Given this list of marker genes VEGFD, BRK1P1, UBE2E4P, NPM1P9, MIR6089, MSL3-DT, RN7SKP290, RPS6KA3, HCCS, RPS27AP17, PDHA1, TXLNG, SH3KBP1, RNU4-6P, RPL30P15, DRAXINP1, PDCL2P1, VCX, RPS5P8, HADHBP1, NHS-AS1, LINC03113, SMS (spermine synthase), TMSB4X, HIKESHIP1, FAM9CP1, RNU6-266P, SMPX, ENSG00000201467, MTND6P12, ASB9, LIMK2P1, RN7SKP183, ENSG00000288706, KRT18P53, SNRPEP9, BCLAF3, SCARNA23, PRDX4, WWC3-AS1, H2BP7, SHROOM2, CBLL2, RN7SL658P (RNA, 7SL, cytoplasmic 658, pseudogene, NCBI Gene Id 106480524), GYG2-AS1, REPS2, PDK3, ENSG00000283380, ENSG00000235834, POLA1, XG, MTCYBP12, ASMTL-AS1 (ASMTL antisense RNA 1), ARSL, ARSD, RPL14P5, CBX1P4, LINC01203, RPL24P9, RNU6-146P, CTPS2, MIR4768, PNPLA4, RN7SL48P, EIF1AX-AS1, EIF1AX, ARSH, AP1S2, RNU6-114P, MIR6086, GEMIN8, LINC03070, FAM9C, LINC02968, MRPL35P4, NHS, PIR, NLGN4X, TLR8, TRAPPC2 (trafficking protein particle complex subunit 2), SETP15, METTL15P3, GPR143, FABP5P13, CBX1P2, ASMTL, PCYT1B, RARRES2P3, LINC03112, ASMT, ACE2-DT, ARHGAP6, MIR651, CLTRN, RPL12P49, ASB11, ENSG00000236513, RBBP7, FAM3C2P, FAM9A, CD99, GYG2, BEND2, FRMPD4-AS1, TBL1X, P2RY8, DHRSX-IT1, VCX2, RNU5F-7P, INE2, APOO, DDX53, MDM4P1, SCML2, HMGN1P33, CA5BP1, IL3RA, SNORA48B, CDKL5, GRPR, CLCN4, S100G, BMX, PRKX, MID1, LINC01546, ENSG00000238764, SUPT20HL2, RNA5SP498, ZBED1, ACOT9, PTCHD1, PIGA, GTPBP6, OFD1, EIF5P1, RPS26P58, ENSG00000201407, MXRA5, PPEF1, RPL9P7, EGFL6, AKAP17A, CLDN34, RPL6P30, MAP3K15, FANCB, SAT1, PUDP, LINC00102, RAB9A, CHP1P3, SHOX, LINC02154, YY2, ASS1P4, PCYT1B-AS1, MIR548AX, PRPS2, PLCXD1, CYTH1P1, HCCS-DT, ADGRG2, SLC35C2P1, RN7SL578P, GPX1P1, ZRSR2, GJA6P, WWC3 (NCBI Gene Id 55841), RNU6-133P (RNA, U6 small nuclear 133, pseudogene), SLC25A6, GOT2P7, MAGEB17-AS1, SUPT20HL1, EEF1B2P3, CD99P1, PHEX, MIR548AM, ZFX, TLR8-AS1, MAGEB17, RN7SKP20, RPS27AP20, VCX3B, LINC00685, EIF5P2, TLR7, SAT1-DT, KLHL15, MIR4767, GS1-600G8.3, RNA5SP499, ARSF, CXorf58, KLHL34, SYAP1, LINC01456, ZFX-AS1, RAI2, MIR3690, PHKA2-AS1, RS1 (NCBI Gene Id 6247), LINC03114, MOSPD2, RNU6-800P, TMSB10P2, ATXN3L, ARSD-AS1, ENSG00000201660, PTCHD1-AS (PTCHD1 antisense RNA (head to head)), SCML1, ACE2, LINC00106, PPP2R3B, MIR23C, RPS24P21, CA5B, HAUS1P2, TPT1P14, PHKA2, ENSG00000200620, PPEF1-AS1, DHRSX, PRKX-AS1, NOLC1P1, MSL3, RPL17P49, FAM136GP, AMELX, ANAPC15P1, MBTPS2, FRMPD4, CNKSR2 (connector enhancer of kinase suppressor of Ras 2), ANOS1, MAP7D2, CRLF2, TCEANC, GPM6B, MIR4770, RNU7-56P, VCX3A, EIF2S3, FAM9B, STS, PSMA6P2, BLOC1S6P1, CSF2RA, GLRA2, RPL35AP37, here is a description of the gene set: studied in species Homo sapiens Human Gene Set: chrXp22